Given this list of marker genes Ager, Stat3, Epha4, Aph1a, Efna3, Efna1, Vsir, Sfrp2, Aph1c, Aph1b, Mbp, Ncstn, Lyn, Psenen, Prelid1, here is a description of the gene set: Any process that increases the frequency, rate or extent of endopeptidase activity, the endohydrolysis of peptide bonds within proteins. studied in species Mus musculus Mouse Gene Set: GOBP_POSITIVE_REGULATION_OF_ENDOPEPTIDASE_ACTIVITY